The following is a description of a gene set: Reactome Pathway: Downregulation of ERBB4 signaling species: Homo sapiens WW-domain binding motifs in the C-tail of ERBB4 play an important role in the downregulation of ERBB4 receptor signaling, enabling the interaction of intact ERBB4, ERBB4 m80 and ERBB4 s80 with NEDD4 family of E3 ubiquitin ligases WWP1 and ITCH. The interaction of WWP1 and ITCH with intact ERBB4 is independent of receptor activation and autophosphorylation. Binding of WWP1 and ITCH ubiquitin ligases leads to ubiquitination of ERBB4 and its cleavage products, and subsequent degradation through both proteasomal and lysosomal routes. In addition, the s80 cleavage product of ERBB4 JM-A CYT-1 isoform is the target of NEDD4 ubiquitin ligase. NEDD4 binds ERBB4 JM-A CYT-1 s80 (ERBB4jmAcyt1s80) through its PIK3R1 interaction site and mediates ERBB4jmAcyt1s80 ubiquitination, thereby decreasing the amount of ERBB4jmAcyt1s80 that reaches the nucleus. part of: Signaling by ERBB4, and this is the list of marker genes: WWP1, UBC, ERBB4, NEDD4, SRC, RPS27A, UBB (ubiquitin B), ITCH, UBA52